The following is a description of a gene set: from publication Hu X, Park-Min KH, Ho HH, Ivashkiv LB (PMID 16148108) IFN-gamma transcriptional responses in control and IFN-gamma primed primary human macrophages Human Gene Set: GSE1925_CTRL_VS_3H_IFNG_STIM_MACROPHAGE_DN species: Homo sapiens Genes down-regulated in macrophages: untreated versus stimulated by IFNG for 3h., and this is the list of marker genes: SCN10A, LZTR1, CCDC88A, SERPINE2, HIP1 (huntingtin interacting protein 1), BCKDHB, TUFT1 (tuftelin 1), TBC1D22A, TUBA1C, AGTR1, RALYL, LIPG, DEFB126, ADCY6, SCN9A, GPX5, RMND5B, KRT2, C4BPB, GABRB2, MED8, SLCO1A2, FRMD4B, CD177, TMPRSS11D, GOT1, HYAL4 (hyaluronidase 4), DCT, BCCIP, SYNDIG1, KIF1B, SPAM1, CCL23, CD80, MS4A6A, OGFRL1, DUOX2, UROD, TMEM186 (transmembrane protein 186), PREB, CHST3, ZNF35, CLMN, CCR4, NUDT13, HAND2-AS1, CCT4, PPL, NQO2, AQP1, H3C6, CUX1, SPIN1, ACO1, DEFA4, GPR19, ADAM11, KCNJ15, SH3BP4, GP5, RNF130, CADPS, IL1RL1, TSBP1, DNAJA4, GOT2, RABAC1, NACC2, SLC37A4, PEX2, BRAF, PNPLA4, VDAC2, SHB, OR2C1, HSPA2, SLC7A2 (NCBI Gene Id 6542), CPA3, NECAB3, MAGEA12, MIF, FGF20, JUN, KCNK12, SLC19A3, FAM168B, DIABLO, ZNF43, PIM1, FOXN3-AS2, DUSP1, CRISP2, KIR2DS2, VNN1, GABRB1, HS3ST3B1 (heparan sulfate-glucosamine 3-sulfotransferase 3B1), PLAT, CDR1, ATP4B, AQP4, SPARC, SLC34A1, SLC34A2, CPB1 (NCBI Gene Id 1360), ZCCHC4, GARNL3, PSG3, VWF (NCBI Gene Id 7450), SLC12A2, HPR (NCBI Gene Id 3250), STX12, DSTYK, CD33, PTPN1, LTA4H, IFNG, RPL13, MNDA, MYOZ3, RGS17, CCNT1, MGLL, TNFRSF21, PRAMEF12, AKR1A1, CTAGE11P, LHX2, KCND2, CYP4F11, TTR, EDA2R, EPRS1, CYP7B1, TRAF3IP2, COL19A1, CD1C, MFAP5, ZNF197, LSM7, PIGR, AURKAIP1, TMEM158, POU3F2, FCGR1A, HBBP1, ARFIP2, EFNA5, RORB, CTAGE1, SLC2A1, NYNRIN, ANXA3, TDP1, ANGPT4, RIC3, DGKG (diacylglycerol kinase gamma), CST7, ARPP21, EPB41L4B, GRK4, SYT13, ZDHHC8BP, RNF185, STON1, SLC22A1, BCHE, ASB4, PLPPR1, EMSY, DCAF17 (DDB1 and CUL4 associated factor 17), ENSG00000237250, CLIC2, SLC25A3 (NCBI Gene Id 5250), IPO4, EPAS1, YIPF1, ENSG00000291006, IFNA6 (interferon alpha 6), PCDHB8, ZBTB38, ST3GAL6, RNF24, UBE2NL, GLRA3, RPL3, ECM2, NLE1, ABHD5, UCP2, HBQ1, IFT70A, TFF1, DNAJC12, EIF4G3, TRH, TPST2, IL18RAP, CD24, NET1